The following is a description of a gene set: The process of conversion of fast-contracting muscle fibers to a slower character. This may involve slowing of contractile rate, slow myosin gene induction, increase in oxidative metabolic properties, altered electrophysiology and altered innervation. This process also regulates skeletal muscle adapatation. species: Homo sapiens Human Gene Set: GOBP_TRANSITION_BETWEEN_FAST_AND_SLOW_FIBER, and this is the list of marker genes: ATP2A2, TNNC1, TNNI1, MIR499A, PPP3CA, MYH7, ACTN3, TNNT1, MIR208B